Given this list of marker genes IL6, TLR7, CFLAR, BATF, IL2RA, ANKRD33B, BCL6, MTMR9, SELL, BHLHE40, KLF13, CCN2, KMO, STK4, GSR, HOMER2, GNG2, SAMSN1, FGL2, CLTC, MAP3K5, CD79B, RPL5, PHF20L1, NFIL3, ZBED2 (NCBI Gene Id 79413), SPAG1, PPP2CA, TNFRSF11A, CCL4, EBF1, CCL5, SLC39A8, ALOX5, APPL2, SLC15A2, IRF8, PDE7A, SEL1L3, SMARCA2, SLA, EIF4G1, METTL14, MTCL1, ATXN1, LY75, XBP1, CTSD, NEK6, NCOA3, HOXC4, VEGFC, MGLL, WT1, CNTN6, STAT4, BCKDK, EGR1, SOCS1, CD86, PPP6C, GNAS, IL4R, PKN2, QSOX1, PEG10 (NCBI Gene Id 651242), VCL, TNFAIP3, HUWE1, CMTM6, RASGRP3, MOK, EVI2A, FCER2, HLA-DRB5, PMAIP1, HLX, ATPAF1, ARPC5, MAL, GCSAM, SPINT2, TLR3, RGS6, MRPS15, NCF2 (neutrophil cytosolic factor 2), CISH, SIAH2, CD69, RPS2, NFKBIZ, here is a description of the gene set: Human Gene Set: LU_IL4_SIGNALING Genes up-regulated in peripheral B lymphocytes after incubation with IL4 for 4 h. studied in species Homo sapiens from publication Lu X, Nechushtan H, Ding F, Rosado MF, Singal R, Alizadeh AA, Lossos IS (PMID 15591113) Diffuse large B-cell lymphomas (DLBCLs) can be subclassified into germinal center B-cell (GCB)-like and activated B-cell (ABC)-like tumors characterized by long and short survival, respectively. In contrast to ABC-like DLBCL, GCB-like tumors exhibit high expression of components of the interleukin 4 (IL-4) signaling pathway and of IL-4 target genes such as BCL6 and HGAL, whose high expression independently predicts better survival. These observations suggest distinct activity of the IL-4 signaling pathway in DLBCL subtypes. Herein, we demonstrate similar IL-4 expression but qualitatively different IL-4 effects on GCB-like and ABC-like DLBCL. In GCB-like DLBCL, IL-4 induces expression of its target genes, activates signal transducers and activators of transcription 6 (STAT6) signaling, and increases cell proliferation. In contrast, in the ABC-like DLBCL, IL-4 activates AKT, decreases cell proliferation by cell cycle arrest, and does not induce gene expression due to aberrant Janus kinase (JAK)-STAT6 signaling attributed to STAT6 dephosphorylation. We found distinct expression profiles of tyrosine phosphatases in DLBCL subtypes and identified putative STAT6 tyrosine phosphatases-protein tyrosine phosphatase nonreceptor type 1 (PTPN1) and PTPN2, whose expression is significantly higher in ABC-like DLBCL. These differences in tyrosine phosphatase expression might underlie distinct expression profiles of some of the IL-4 target genes and could contribute to a different clinical outcome of patients with GCB-like and ABC-like DLBCLs.